The following is a description of a gene set: species: Homo sapiens Human Gene Set: GOBP_MITOCHONDRIAL_ADP_TRANSMEMBRANE_TRANSPORT The process in which ADP is transported across a mitochondrial membrane, into or out of the mitochondrion., and this is the list of marker genes: SLC25A6, SLC25A31, SLC25A41, SLC25A5, SLC25A4